Given this list of marker genes Nicn1, Abhd14b, Cish, Mir2136, Bsn, Mst1, Rbm15b, Col6a5, Grm2, 4930447F24Rik, Gm29521, Hmgb1-rs16, Hyal2, 4930524O07Rik, Gm22595, Amigo3, Rbm5, Cyb561d2, Ifrd2, Sema3f, Gm23856, Gm22720, Cpne4, Parp3, Tusc2, Acp3, Cep63, 4930535L15Rik, Trf, Gm24631, AA543401, Cdhr4, Slco2a1, Gm34106, Gm19667, Gm23595, Iqcf4 (NCBI Gene Id 67320, IQ motif containing F4), Gm5621, Glyctk (glycerate kinase), Cacna2d2, Pcbp4, Mir7088, Gm9917, Ephb1, Rbm6, Gm5372, 4930429P21Rik, Gm28548, Hemk1, Gmppb, Uba7, Hyal1, Gm9451, Actl11, Naa80, Dag1, Gm17141, Gm29154, 5830418P13Rik, Col6a4, Ackr4, Rrp9, Gnai2, Wdr82, 9630041A04Rik, Gm18655, Cdv3, Inhca, Amotl2, Mir7243, Rpl29, Manf, Dusp7, Mst1r, Gm7364, Nudt16l2, Tlr9, Slc38a3, Uba5, Iqcf6, Ip6k1, A930036K24Rik, Ky, Gm19721, Mon1a, Gpr62, Gm32743, 6430571L13Rik, Mirlet7g, Alas1, Dock3, Lsmem2, Inka1, Gm28111, Tex264, Atp2c1, Hyal3, Gm22454, Apeh, Acy1, Dnajc13, Bfsp2 (NCBI Gene Id 12076, beaded filament structural protein 2, phakinin), Poc1a, Rad54l2, D030055H07Rik, Srprb, Tmem108, 1700039M15Rik, Gm7436, Col6a6 (NCBI Gene Id 245026), Gm17205, 4930533D04Rik, Mir135a-1, Pik3r4, Nek11, Gm31326, 4930517N10Rik, 4930500F10Rik, Gm5627, Amt, n-R5s88, Gm33054, Ryk, Rhoa, Mrpl3, Ppm1m, Sema3b, Dcaf1, Gm16252, Acad11, Nphp3, Gnat1 (NCBI Gene Id 14685), Nprl2, Gm37201, 4932413F04Rik, Nudt16, Rnf123, Traip, Tmem115, Iqcf1, Abhd14a, Rassf1, Gm25904, Aste1, Iqcf5, Topbp1, Tcta, Anapc13, Gm29387, Zmynd10, Gm17040, Twf2, Camkv, Gm28996, Rab6b, Mapkapk3, Gm17950, here is a description of the gene set: Mouse Gene Set: chr9F1 species: Mus musculus